The following is a description of a gene set: Decreased levels of immunoglobulin A (IgA). Decreased circulating IgA concentration Human Gene Set: HP_DECREASED_CIRCULATING_IGA_CONCENTRATION species: Homo sapiens, and this is the list of marker genes: PMM2, IQSEC2, LIG1, NFKB2, IGLL1, BACH2, DNMT3B, HLA-DQB1, SYK, JAK3, ATM, ORAI1, CSNK2A1 (NCBI Gene Id 1457), IL2RA, DOCK11, CBLB, RAG2, RFX5, IKBKG, TNFRSF11A, PIGG, IGHG2, CD247, CASP8, DCLRE1C, TNFRSF13C, TCN2, ICOS, PSMB10 (NCBI Gene Id 8138), CR2, IRF2BP2, SPI1, TCF3, PIK3R1, CTLA4, REL, IPO8, BLNK, RFXAP (NCBI Gene Id 5994), SASH3, IVNS1ABP, CD79B, CAVIN1, TNFRSF13B, IL2RG, ZNF341, FLII, PLCG2, NFKBIA, PIGT, TYMS, POLD1, ATP6AP1 (ATPase H+ transporting accessory protein 1), IL6ST, BLM, PIK3CG (phosphatidylinositol-4,5-bisphosphate 3-kinase catalytic subunit gamma), UNG, CARD11, SEC61A1, CD40, CPLX1, ALG12, TOM1, STIM1, CD19, PRIM1, HLA-DQA1, RAI1, KDM6A, CTBP1, ITCH, LRBA, RAG1, STAT2 (NCBI Gene Id 6773), LYN, CD3E, NELFA, RNF168, LCK, IGKC, MTOR, BTK, LETM1, NSD2, ADA, LAT, MOGS, PTPRC, MAP3K14, KMT2D, AICDA, ZBTB24, CD40LG, DEAF1, CD3D, KNSTRN, NFE2L2, PIK3CD